Given this list of marker genes Cct5, Terf2ip, Cct8, Pml, Cct4, Acd, Pinx1, Atr, Cct7, Wrap53, Zfp827, Potefam3a, Tnks2, Cct3, Tnks, Cct6a, Terf1, Spdya, Tcp1, Gnl3l, Nabp2, Tert, Brca2, Tpp1, Pot1b, Cct2, Pot1a (protection of telomeres 1A), Tinf2, Atrx, Gnl3 (NCBI Gene Id 30877), Potefam3b, Ankrd66, Terf2, Macroh2a1, Dkc1, Xrcc5, here is a description of the gene set: Any process in which a protein is transported to, or maintained at, the telomeric region of a chromosome. studied in species Mus musculus Mouse Gene Set: GOBP_PROTEIN_LOCALIZATION_TO_CHROMOSOME_TELOMERIC_REGION